The following is a description of a gene set: species: Homo sapiens Human Gene Set: MANNO_MIDBRAIN_NEUROTYPES_HNBML1 Cell types are named using anatomical and functional mnemonics prefixed by 'm' or'h' to indicate mouse and human respectively: OMTN, oculomotor and trochlear nucleus; Sert, serotonergic; NbM, medial neuroblast; NbDA, neuroblast dopaminergic; DA0-2, dopaminergic neurons; RN, red nucleus; Gaba1-2, GABAergic neurons; mNbL1-2, lateral neuroblasts; NbML1-5, mediolateral neuroblasts; NProg, neuronal progenitor; Prog, progenitor medial floorplate (FPM), lateral floorplate (FPL), midline (M), basal plate (BP); Rgl1-3, radial glia-like cells; Mgl, microglia; Endo, endothelial cells; Peric, pericytes; Epend, ependymal; OPC, oligodendrocyte precursor cells. from publication La Manno G, Gyllborg D, Codeluppi S, Nishimura K, Salto C, Zeisel A, Borm LE, Stott SRW, Toledo EM, Villaescusa JC, Lönnerberg P, Ryge J, Barker RA, Arenas E, Linnarsson S (PMID 27716510), and this is the list of marker genes: MAP7D2, STMN1, RAB3C, FGF9, ROBO1, SEMA3E, VASH2, MAPK8, SLC17A6, CSMD3, CELF6, XIST, FGF14, LRRTM4, CD24, NELL2, KCNA3, ELAVL2, NSG1, BZW2, FMN2, KLHL35, YPEL4, PHF21B, MCF2L, GNG2, C2CD4C, RBFOX2, TAC1, EPHA8, CNTN2, ONECUT2, SAMD5, ZMAT4, ACVR2B, GDAP1L1, MSI1, PITX2, GSE1, FOXD2, MIAT, SCN8A, KLHL32, RUFY3 (RUN and FYVE domain containing 3), SYCP2, NUAK1, PRRT2, PRKACB, JUP, EBF3, C1QL1, EPB41, NALF1, EDIL3, MPP3, KIF3C, RNF175, MIR7-3, GNG3, AKR1C2, GAP43, PCSK1N, ARPP21, UBE2QL1, ETFB, NKX6-2, FOXD2-AS1, GABRG2, ZNF521, CXADR, CBLN2, PKP2, PALB2, TMEM169 (transmembrane protein 169), PCDH11X (protocadherin 11 X-linked), RPL13AP5, CLCN4, PHACTR3, FNIP2, JPH4, AKR1C1, RAPGEF5, ROBO2, SLC4A8, TSIX, CNR1, NAPB, DOCK4, XPR1, RUSC1, SCG5 (secretogranin V), KCTD4, LCOR, LHX1, NCAM1, NAP1L3, MYO5A, THSD7A, SYBU, PHYHIPL, PTPN3, PRKAR2B, ST6GAL1, MSANTD3-TMEFF1, SYT6, AP1S2, PAK5, SCAMP5, SYN3, BIN1 (NCBI Gene Id 274), PSD2, SRSF12, NMNAT2, ZC3H8, SYT4, GSDME, TAGLN3, NDRG4, POU2F2, SHISA6, PHLDA1, CACNG7, NXPH4, SRGAP1, VWDE, MAPRE3 (microtubule associated protein RP/EB family member 3), TOX3, NRN1, TRIM36, TMEM132B, CMIP, SV2A, CACNB4, PAK3, KIF21A (NCBI Gene Id 80819), DCX, ACVR1B, SCUBE1, UNC13A, CSRNP3, PGM2L1, LRRC55, RASGEF1B, MCF2, RHOU, DOCK3, RAP1GAP2, YWHAG, TMSB15A, PLPPR1, ELAVL3, OLFM1, SYT7, GPM6A, GNAL, DOK6 (NCBI Gene Id 220164), GRIA2, NFASC, NREP, MAPK8IP2, SLC22A15, ANK3, ZNF878, MSANTD3, SMPD3, PCDH9, CELSR3, ONECUT1, MAP2, NNAT, PLCL1, NAV1 (NCBI Gene Id 89796), USP44, MACROH2A2, KIF21B, RPS6KA2, ENTREP2, ATCAY, KIF26A, RAB3A, AMER2, UCHL1, TRMT13, BASP1, GPR12, CCDC122, PER1, ASXL3, TUBB3, ITGA6, ATL1, ST8SIA3, ADA2, TMEM196, TMEM178A, KCNH8, NDST3, SCG3, ANK2, PTPN5, TLCD3B, KIF5C, INSM1, MYT1, DCC, FOXP2, TBC1D3, FHOD3, RNF112, FOXA2, CTNNA2, INA, ACTL6B, SHROOM2, ARFGEF3, ZNF737, WNT7A, SVOP, MAML3 (mastermind like transcriptional coactivator 3), SH3PXD2A, SLC38A1, EBF1, TULP4, RIPOR2, SEMA3A, CD2, MIR124-2HG, CELF3, TAFA2, NHLH2, TSC22D1-AS1, CYRIA, ATP11C, CRMP1, BCL11A, CADPS, KLC1, ENSG00000248540, SNAP91, SOX4, CDK5R1, PCSK1, MAP1B, SBK1, PLPPR3, CACNB3, SEZ6L2, TUBB2B, DSCAM, ARK2C, RAB9B, SMIM18, DPYSL3, MICAL1, NKAIN2, SEZ6L, TMEM35A, ZBED10P, LRRC49, MAPK6, SIM1, DTD1, RUNDC3A, ASIC4, TRIM67, GPRIN3, MAST1, RPL23A, LPCAT4, CXXC4, HS6ST3, NEGR1 (NCBI Gene Id 257194), TENM1, KCNQ3, GLRA2, ZBTB6, SRRM4, ISLR2, PAFAH1B3, MLLT11, ASPA, PEX5L, ASNS, FOXA1, ZBTB38, PLCXD3, TUBA1A, LPAR2, OCIAD2, TTC9B, DUSP26, GPC2, SNAP25, RTN1, POU3F2, RPS19, LINGO1, GRM4, CELF5, GP1BB, GRIN3A, POU3F1, PDE1A, C1QL4, SHISA2, SPINT2, XKR4, DRD2, FGF12, C1orf35, CCDC184, PLEKHA6, ZNF697, PDZD7, MAP6, CCBE1, GABRB3, NYAP1, ATP1A3, STMN2, ELAVL4, SCN3A (sodium voltage-gated channel alpha subunit 3), SLC37A1, IGSF9, OLFM3, SOX11, BRSK2, PCBP4